Given this list of marker genes JAM3, CX3CL1, SLAMF8, NINJ1, ALOX5, LBP, S100A8, TRIM55, S100A9, FUT7, ITGB2, SLAMF1, TNF, PTN, MDK, FFAR2, ELANE, SELE, ADAM8, CCR6, RTN4, here is a description of the gene set: The movement of a leukocyte within or between different tissues and organs of the body contributing to an inflammatory response. studied in species Homo sapiens Human Gene Set: GOBP_LEUKOCYTE_MIGRATION_INVOLVED_IN_INFLAMMATORY_RESPONSE